Given this list of marker genes FGFR2, PDGFRL, MSH2, AAGAB, PDGFRA, CCND1, DLC1 (DLC1 Rho GTPase activating protein), SEMA4A, SMAD4, SDHC, KIT, CASP10 (NCBI Gene Id 843), ATM, MUTYH, BRAF (B-Raf proto-oncogene, serine/threonine kinase), KLF6, AURKA (NCBI Gene Id 8465, aurora kinase A), BMPR1A, TERF2IP, MSH6, STK11, IL1RN, BRCA2, SDHB, RAD54B, CDK4, EP300, CEP57, DCC, NRAS, BAP1, ACD, SDHA, ERBB2, AXIN2, BUB1B, BLM, BAX, CTNNB1, EPCAM, TREX1, TLR2, PRKAR1A, IL1B, PIK3CA, PTPRJ, POLD1, COL14A1, MGMT, BUB3, PTPN12, MC1R, AKT1, MCC, APC, PMS1, MLH1, FGFR3, CDKN2A, MDM2, SRC, CDKN2B, POT1, PDE11A, TRIP13, FLCN, MLH3, MITF, MSH3, BUB1, CHEK2, KRAS, TERT, IRF1, PLA2G2A, PMS2, TP53, RPS20, ENG, POLE, PTCH1, BCL10 (BCL10 immune signaling adaptor), TGFBR2, CDH1, here is a description of the gene set: A tumor (abnormal growth of tissue) of the stomach. studied in species Homo sapiens Human Gene Set: HP_NEOPLASM_OF_THE_STOMACH Neoplasm of the stomach